The following is a description of a gene set: Tracheomalacia Human Gene Set: HP_TRACHEOMALACIA species: Homo sapiens, and this is the list of marker genes: TRRAP, RAB3GAP2, TONSL, PAX3, SETD2, TRIM2, EHMT1, MID1, FGFR2, PRRX1 (paired related homeobox 1), WDR26, HK1, LTBP4, FLNB, POLR1A, SNRPB, USP9X, BMPER, ZNF699, RALGAPA1, AMER1, EMC1, ESAM, HDAC4, GMNN, KANSL1, RAC1, POLG, MYRF, SOX9, AFF4, ERF, SCUBE3, SLC26A2, RAP1B, CHD6, COL2A1, AHDC1, MYCN, FAT4, DCHS1, KMT2C, HRAS, RPL5, ORC4, KIF22, ORC6, B3GALT6, IDS